Given this list of marker genes Cd8a, Lilrb4a, Sart1, Lilrb4b, Tnfsf9, Hsp90aa1, here is a description of the gene set: species: Mus musculus The process in which a relatively unspecialized T cell acquires specialized features of a cytotoxic T cell. Mouse Gene Set: GOBP_CYTOTOXIC_T_CELL_DIFFERENTIATION